Given this list of marker genes C10orf90, NPM1, VPS4B, PLK2, TMEM67, MDM1, GEN1, PPP1R35, RAB6C, CDK5RAP2, CHMP5, CCDC15, CENPJ, NUBP1, RBM14, CEP295NL, ROCK2, CHMP4C, CEP76, CHMP3, CHMP4B, NUP62, CHORDC1, BRCA1, CEP131, CCNF, CHMP2A, SASS6, CENATAC, PDCD6IP, ALMS1, CEP120, NAT10, XRCC3, CHMP1B, CHMP2B, PKHD1, SPICE1, POC1B, XPO1, KAT2A, STIL, POC1A, SIRT1, PLK4, KAT2B, TRIM37, CHMP1A, FBXW5 (F-box and WD repeat domain containing 5), CEP295, here is a description of the gene set: Human Gene Set: GOBP_REGULATION_OF_CENTROSOME_DUPLICATION Any process that modulates the frequency, rate or extent of centrosome duplication. Centrosome duplication is the replication of a centrosome, a structure comprised of a pair of centrioles and peri-centriolar material from which a microtubule spindle apparatus is organized. studied in species Homo sapiens